The following is a description of a gene set: Any structural anomaly of the Z disk, which is the platelike region of a muscle sarcomere to which the plus ends of actin filaments are attached. species: Homo sapiens Human Gene Set: HP_ABNORMAL_Z_DISK_MORPHOLOGY Abnormal Z disk morphology, and this is the list of marker genes: KY, LMOD2, SQSTM1, ACTN2, FXR1, UNC45B, SNUPN, CFL2, TNNT1, DES